The following is a description of a gene set: Any process that results in a change in state or activity of a cell or an organism (in terms of movement, secretion, enzyme production, gene expression, etc.) as a result of an oxygen radical stimulus. An oxygen radical is any oxygen species that carries a free electron; examples include hydroxyl radicals and the superoxide anion. Human Gene Set: GOBP_RESPONSE_TO_OXYGEN_RADICAL species: Homo sapiens, and this is the list of marker genes: NOS3, ATP7A, MB, SOD2, GCH1, SOD3, PRDX2, UCP2, NQO1, UCP3, ADPRS, DHFR, APOA4, TXNRD2, SOD1, CCS, MPO, MT3, PARK7, ERCC6, DHFRP1 (NCBI Gene Id 643509), CD36, CYGB, FBLN5, BMP7, NFE2L2, PRDX1